The following is a description of a gene set: from publication Good KL, Avery DT, Tangye SG (PMID 19124732) Human Gene Set: GSE13411_IGM_MEMORY_BCELL_VS_PLASMA_CELL_DN species: Homo sapiens Enhanced secondary Ab responses are a vital component of adaptive immunity, yet little is understood about the intrinsic and extrinsic regulators of naive and memory B cells that results in differences in their responses to Ag. Microarray analysis, together with surface and intracellular phenotyping, revealed that memory B cells have increased expression of members of the TNF receptor, SLAM, B7 and Bcl2 families, as well as the TLR-related molecule CD180 (RP105). Accordingly, memory B cells exhibited enhanced survival, proliferation and Ig secretion, as well as entered division more rapidly than naïve B cells in response to both T-dependent and T-independent stimuli. Furthermore, both IgM and isotype switched memory B cells, but not naïve B cells, co-stimulated CD4+ T cells in vitro through a mechanism dependent on their constitutive expression of CD80 and CD86. This study demonstrates that upregulation of genes involved in activation, co-stimulation and survival provides memory B cells with a unique ability to produce enhanced immune responses and contributes to the maintenance of the memory B cell pool. Genes down-regulated in comparison of IgM-memory B cells versus plasma cells., and this is the list of marker genes: CRNN, SUOX, GAB1, PIM2, KCNMB1, SDS, STC1, BIRC5, AGTR2, QPRT, NPBWR2, CPT2, ASRGL1, GAS8, CDT1, CHST11, SLC3A2, EXO1, HSD17B3, TNFRSF17, TPX2, PYCR1, TIMP1, MCHR1, TSHR, FKBP2, PFKFB1, OAZ3, DNAJC3, SPAG5, FAM204A, RABEPK, MMP15, KIAA0513, ASF1B, OR1G1, HSPA1L, NEU1, FAM149A, VKORC1, TRPM3, GMPPB, GID4, NOC2L, CALU, GPRC5D, NRGN, IGKC, P4HB, ITGBL1, SMCO4, SHC3, MYO1D, MAT1A, CDH15, PINK1, TNC, H4C5, KIF22 (NCBI Gene Id 728037), CCNL2, HPCAL4, RAB30, FLT3, H2BC6, PDE4A, SSH3 (slingshot protein phosphatase 3), NPHS2, CTNND2, BMS1P20, H4C4, IGKV1-5, CLPTM1, SULF1, LANCL2, SEC14L1, AGPAT4, UCHL1 (ubiquitin C-terminal hydrolase L1), PGLYRP1, EFCAB2, APOL6, DHRS9, HOXB2, NT5DC2, TTC23, CCR10, LAMC1, LYPLA2, MASP1, PRDM1, CDK1, CD320, SERPINA4, CTH, IGLJ3, CDC45, BRAP, GSTM3, KIF18B, KCNA3, MYL4, MYF6, DUSP7, SEL1L, CLPB, KDELR2, UBE2C, HMGB3P1, NXPE4, SMPX, H3C12, FKBP11, COPZ2, ASS1, DNAJC1, TROAP, OPTN, XBP1, OR7E87P, TTYH1, SERPINA2, IER3, H2BC17, COG4, BRINP2, CEP85, EHHADH, IGKV1D-13, RAD54L, MORC1, SOX30, CHPF, ELL, AKR1C3, IGLL3P, SCAMP5, WBP4, RUNX1, ADGRE3, LORICRIN, SPOCK1, IBA57, NFE2L3, TSSK2, SPICE1, SLCO5A1, BLM, CD207, CAMK1G, ZKSCAN8, SPINK1 (serine peptidase inhibitor Kazal type 1), HTRA1, CTTN, IL5RA, GSG1 (NCBI Gene Id 83445), ZNF814, TIMP4, EPHX2, TK1, PRKAR2B, NRN1, CDKN2A, HSD17B6, BCKDK, PPIB, AQP3, IGKV4-1, EFCAB6, INTS5, GUSBP11, DOLK, ICOS, TIMM44, DARS2, YIPF2, PXMP2, KLK3, EYA1, EPPK1, GUCY1A2, MYH3, CYP2E1 (NCBI Gene Id 1571, cytochrome P450 family 2 subfamily E member 1), SMPDL3B, LAMP5, PTP4A3, RRBP1, HAX1, BTD, ANXA2, DHDDS, SARS2, SDC1, SEMA4A, RND1, PLXDC1 (NCBI Gene Id 57125), ALLC, PLK1, ZBP1, CDC25A